The following is a description of a gene set: species: Mus musculus This event has been computationally inferred from an event that has been demonstrated in another species.<p>The inference is based on the homology mapping from PANTHER. Briefly, reactions for which all involved PhysicalEntities (in input, output and catalyst) have a mapped orthologue/paralogue (for complexes at least 75% of components must have a mapping) are inferred to the other species. part of: Signaling by FGFR3 Reactome Pathway: Negative regulation of FGFR3 signaling electronically inferred by orthology from the curated human pathway, and this is the list of marker genes: Rps27a, Fgf5, Spry2, Fgf8, Frs2, Fgf17, Fgf20, Fgf2, Fgf1, Cbl, Grb2, Ubb, Fgf4, Mapk3, Fgf16, Fgf23